The following is a description of a gene set: from publication Chen Y, Wang X (PMID 31504780) Genes predicted to be targets of miRBase v22 microRNA hsa-miR-6887-3p in miRDB v6.0 with MirTarget v4 prediction scores > 80 (high confidence targets). Human Gene Set: MIR6887_3P species: Homo sapiens, and this is the list of marker genes: PCDHA2, CAMTA1, MARK2, CITED4, PCDHA11, JARID2, AAK1 (NCBI Gene Id 652453), SLC6A17, TNRC6B, ELFN2, CNPY2, MYO10, PEA15, ADPRS, RPRD2, GTPBP1, TRAM2, RASGEF1B, EYA2, ITPR2, CLDN4 (NCBI Gene Id 1364), FOXO4 (forkhead box O4), ATPSCKMT, TMEM95, XKR7, ARPC1B, B4GALT6, PLPP4, LHFPL4, TBC1D16, SNN, PCDHA4, ZNF512B, TTC7A, FCHSD2, MLEC, AGPAT1, MAG, USP14 (ubiquitin specific peptidase 14), ERP44, KATNIP, FCHSD1, PNMA1, PIM2, TMEM198, NAT14, DAB2IP, B4GALT2, EPHB2 (EPH receptor B2), ZNF385A, AGAP1, KPNA6, ILVBL, POLDIP3, UEVLD, PSD3, EFR3B, PLXNA1, HPCA, KIF6, ANKRD65, ATP8B3, PLXND1, SOX9, PEDS1, KAT8, GFAP, PDE7A, SFXN5, STIP1, SOCS3, TLE4, POMP, PHF2, OPN1MW, NTM, DNAJB2, PNMA3, ZNF740, HMGXB3, MLLT6, AQP1, CACNA2D1, OIP5, PCDHA12, FBXO32, PLPP2, HEY1, LARP4, ARHGAP10, RPL32, PCDHA1, GABARAP, CBX1, PIGH, SPTBN4, PCDHA8, WT1, PKNOX2, PPP4R3A, EPHB4, CCDC120, NBL1, SOX11, PCTP, SYNGAP1, NFIX, TSPAN16, SEMA3G, ANKRD42, IPO5, RPL28, CASP2, ASIC4, IGF2, CALM1, PCDHA7, CADM4, PITPNM3, TSPOAP1, SH2D5, C3orf18 (chromosome 3 open reading frame 18), MS4A15, SPATS2, IPO7, OTUD7B, RIMS4, BRSK1 (BR serine/threonine kinase 1), NXPH3, ZNF780A, BLCAP, PGM5, KSR2, NSD1, VCPIP1, TOMM40, ANKRD52, AOC3, PCDHA10, OPALIN, SNX1, NYAP1 (NCBI Gene Id 222950), RND1, HOXA7, TCTN1, PPP1R3C, ADRB1, PGPEP1, SHC3, NEURL1, PARVG (NCBI Gene Id 64098), TNS1, TET3, DHRS7, PCDHAC1, HMGA1, PCDHA3, EIF5A, SDC3, PCDHA6, TNFRSF12A, EPHB3, RNF222, DYNC1LI2, PCDHAC2, ELAVL3, TSPAN5, MEX3A, CHD3, VAV2, SCN2B, APLN, JUNB, FAM241B, SLC6A2, SRCIN1, NSMF, MAP1A, CACHD1, NPAS4, ARK2C, LZTS1, NUFIP2, CXXC4, BCL3, ZNF704, NIBAN2, MIDN, DAG1, MAN2A2, MECP2, ACTN4, MNT, PCDHA5, GRIP1, PCDHA13